The following is a description of a gene set: Any process that stops, prevents, or reduces the frequency, rate or extent of the directed movement of calcium ions into, out of or within a cell, or between cells, by means of some agent such as a transporter or pore. Human Gene Set: GOBP_NEGATIVE_REGULATION_OF_CALCIUM_ION_TRANSPORT species: Homo sapiens, and this is the list of marker genes: NTSR1, GSTO1, FMR1, TMBIM6, EPPIN, MIR424, BCL2, TLR9, CALM3, YWHAE, MIR208A, MIR1-1, MRLN, PLN, ATP1A2, UBQLN1 (NCBI Gene Id 54347), SEMG1, SLC30A1, CALM2, CRHR1, VDAC1, TRIM27, EPO, ADRA2A, REM1, FKBP1B, LILRB2, SLN, GPR35 (G protein-coupled receptor 35), UCP2, TGFB1, MCUB, PPP3R2, MIR328, STC1, PPP3CB, CAV3, UBR3, PPP3CA, HES1, PACSIN3, PPP3CC, BIN1, LILRB1, MIR34A, CACNA1F, NOS1, SESTD1, NOS3, SPINK1, CALCA, INPP5K, PPP3R1, MIR208B, GNB5, CBARP, MIR499A, MIR200C, CALM1